Given this list of marker genes FILIP1, WFS1, SIX3, VPS33B, SHH, HLA-DRB1 (NCBI Gene Id 730415), AKT1, HLA-DPB1, P4HA2, IFT56, GLA, BTNL2, AQP2, STRADA, STIL, PRPS1, OTX2, FGFR1, GPR161, HLA-DPA1, FOXH1, GLI2, ARL6, SMC1A, CTLA4, FGF8, AVP, WDR11, TREX1, ALMS1, BBS1, NODAL, STAG2, CTNNB1, PRTN3, CNOT1 (CCR4-NOT transcription complex subunit 1), PTCH1, POU3F4 (NCBI Gene Id 5456), RNU4-2, ALX3, LHX4, CRLS1, SOX2 (SRY-box transcription factor 2), CDON, HESX1, ARNT2, CISD2, MAP2K1, DLL1, PLCH1 (phospholipase C eta 1), BRAF, DISP1, TP63, GAS1, ROBO1, PTPN22, AVPR2, ZIC2, HLA-B, NRAS, VIPAS39, TGIF1, CRIPTO, SOX3, CCDC28B, PROKR2, OCRL, here is a description of the gene set: Diabetes insipidus A state of excessive water intake and hypotonic (dilute) polyuria. Diabetes insipidus may be due to failure of vasopressin (AVP) release (central or neurogenic diabetes insipidus) or to a failure of the kidney to respond to AVP (nephrogenic diabetes insipidus). studied in species Homo sapiens Human Gene Set: HP_DIABETES_INSIPIDUS